Given this list of marker genes CDR2L, EEA1, CIB2, HECTD3, TLN1, RIMS3, ENO2, ZYG11B, NBL1, SPINDOC, NEUROD2, WNK3, CAVIN1, STIM1, APOA5, THY1, COP1, FKBP10, DLK1, OAF, SCRT2, TMTC3, RBM38, FBXO41 (F-box protein 41), PLEKHS1 (NCBI Gene Id 79949), SYNGAP1, NSG2, TMT1B, IFI6, PCDHB4, PPP4C, NCDN, STMND1, ISLR, PLAC8L1, SLC16A2, PRKACA, NOVA2, HMGCS1, VAT1, S1PR2, MYPOP, CCDC97, SCN4A, CSNK1A1, AGGF1, SVIL, ELK1, ATP2B4, ETNK1, IRGQ, TRAM1, NOVA1, EVC, PPP4R3B, CPSF7, SNCB, FA2H, CHAD, SELENOP, VCAN, RBM14, ELAVL3, BARHL1, SPATA31D3, PDZD7, CSNK1A1L (NCBI Gene Id 122011), AQP2, TAF15, BCAM, CDCA5, NACC1, IFNLR1, CD1E, GPD1, C1orf21, ZNF280B, POU2F2, PA2G4, EGLN2, FGFR1, SPOCK2, SLC25A37, CTIF (cap binding complex dependent translation initiation factor), GATAD2B, FREM1, NHERF1, BRME1, SEZ6L2, TTC9, SMARCC2, KIAA0825, RAB7A, RD3, CPA5, IGFBP5 (insulin like growth factor binding protein 5), SEMA5A, GRIK3, ZNF618, PRX, IRAG2, here is a description of the gene set: Human Gene Set: MIR3150A_3P Genes predicted to be targets of miRBase v22 microRNA hsa-miR-3150a-3p in miRDB v6.0 with MirTarget v4 prediction scores > 80 (high confidence targets). from publication Chen Y, Wang X (PMID 31504780) species: Homo sapiens